Given this list of marker genes Apoc2l, Lrpap1, Vldlr, Apoe, Apoc3, Apoc2, Apoc1, here is a description of the gene set: The process in which a very-low-density lipoprotein particle is removed from the blood via receptor-mediated endocytosis and its constituent parts degraded. studied in species Mus musculus Mouse Gene Set: GOBP_VERY_LOW_DENSITY_LIPOPROTEIN_PARTICLE_CLEARANCE